The following is a description of a gene set: Jaw claudication Human Gene Set: HP_JAW_CLAUDICATION Pain in the jaw or ear induced by chewing or otherwise moving the jaw. species: Homo sapiens, and this is the list of marker genes: PTPN22, SAA1, P4HA2, HLA-B (major histocompatibility complex, class I, B), HLA-DRB1